The following is a description of a gene set: species: Homo sapiens Human Gene Set: HP_CONE_SHAPED_EPIPHYSIS Cone-shaped epiphyses (also known as coned epiphyses) are epiphyses that invaginate into cupped metaphyses. That is, the epiphysis has a cone-shaped distal extension resulting from increased growth of the central portion of the epiphysis relative to its periphery. Cone-shaped epiphysis, and this is the list of marker genes: MRPS28 (NCBI Gene Id 64947), EVC, DYNC2I2, GDF5, SRCAP (Snf2 related CREBBP activator protein), NPR2, DYNC2LI1, CSPP1, SHOX, TRAF3IP1, ADAMTSL2, POC1A, KIAA0586, IFT52 (NCBI Gene Id 51098), PDE3A, FGFR3, COL2A1, INVS, FGF9, BMPR1B, CEP290, FBN1, IFT80, PIK3CD, CEP152, AIFM1, ZMIZ1, KIAA0753, TTC21B, DNA2, TRPS1, KIF15, MIA3, COMP, RUNX2, DYM, NPHP4, RMRP, ATRIP, CEP120, PLK4, TRAIP, PRKAR1A, WDR19, FLNA, PCNT, COG4, TRPV4, SDCCAG8, MIR140, IHH, NPHP1, RSPRY1, EIF2AK3, BGN, TRIP11, SMAD4, NUP85, DYNC2I1, MAP3K7, PDE4D, IQCB1, ATR, CENPE (NCBI Gene Id 1062), IFT172, DYNC2H1, EVC2, NEK1, NSMCE2, NPHP3, OFD1, CDC42BPB, EXT1, NOG, RBBP8, RAD21, IFT140, CEP164, TBC1D2B, KNSTRN, GPX4